The following is a description of a gene set: Binding to a nuclear retinoid X receptor. species: Mus musculus Mouse Gene Set: GOMF_NUCLEAR_RETINOID_X_RECEPTOR_BINDING, and this is the list of marker genes: Nr1h3, Vdr, Nr1h4, Med25, Ncoa2, Nr0b2, Ncor1, Arid5a, Hmga1b, Fus, Tacc1, Hmga1, Pparg, Rarb, Rarg, Nr1h2, Nrip1, Uimc1, Ncoa1 (nuclear receptor coactivator 1), Nsd1, Sumo2, Ncoa6, Ncor2